The following is a description of a gene set: species: Mus musculus Catalysis of the removal of damaged bases by cleaving the N-C1' glycosidic bond between the target damaged DNA base and the deoxyribose sugar. The reaction releases a free base and leaves an apurinic/apyrimidinic (AP) site. Mouse Gene Set: GOMF_DNA_N_GLYCOSYLASE_ACTIVITY, and this is the list of marker genes: Mbd4, Nthl1, Ogg1, Neil3, Tdg, Tdg-ps, Mpg, Pcna, Ung, Smug1, Neil2, Mutyh, Neil1